The following is a description of a gene set: from publication Senese S, Zaragoza K, Minardi S, Muradore I, Ronzoni S, Passafaro A, Bernard L, Draetta GF, Alcalay M, Seiser C, Chiocca S (PMID 17470557) Human Gene Set: SENESE_HDAC1_AND_HDAC2_TARGETS_UP studied in species Homo sapiens Genes up-regulated in U2OS cells (osteosarcoma) upon knockdown of both HDAC1 and HDAC2 by RNAi. Posttranslational modifications of core histones are central to the regulation of gene expression. Histone deacetylases (HDACs) repress transcription by deacetylating histones, and class I HDACs have a crucial role in mouse, Xenopus laevis, zebra fish, and Caenorhabditis elegans development. The role of individual class I HDACs in tumor cell proliferation was investigated using RNA interference-mediated protein knockdown. We show here that in the absence of HDAC1 cells can arrest either at the G(1) phase of the cell cycle or at the G(2)/M transition, resulting in the loss of mitotic cells, cell growth inhibition, and an increase in the percentage of apoptotic cells. On the contrary, HDAC2 knockdown showed no effect on cell proliferation unless we concurrently knocked down HDAC1. Using gene expression profiling analysis, we found that inactivation of HDAC1 affected the transcription of specific target genes involved in proliferation and apoptosis. Furthermore, HDAC2 downregulation did not cause significant changes compared to control cells, while inactivation of HDAC1, HDAC1 plus HDAC2, or HDAC3 resulted in more distinct clusters. Loss of these HDACs might impair cell cycle progression by affecting not only the transcription of specific target genes but also other biological processes. Our data support the idea that a drug targeting specific HDACs could be highly beneficial in the treatment of cancer., and this is the list of marker genes: KISS1, LINC02915, PRDM1 (PR/SET domain 1), CBFB, PSME4, PTBP1, MAP3K7CL, PDE4DIP, TEX261, PRIM2, TASOR2, ELK3, PI3, BCL2L1, MAFF, IL1RAPL1, EXTL3, RBPMS2, IL6R, RPL27A, BMP2, MCL1, SCYL2, GEM (GTP binding protein overexpressed in skeletal muscle), PLEKHB2, OTUB2, DNAJB14, BCL2A1, HAS2, PPIF, TFRC, SNHG16, SCG5, RRAGD, DOCK4 (NCBI Gene Id 9732), JAM3, SLC16A1, TMEM200A, ATP11B, NTAQ1, MMP9, DDX42, RAC2, NAV3, SAA1, IL13RA2, IRAK2, HIP1 (huntingtin interacting protein 1), GCH1, BIRC3, HHIP, FN1, FGFRL1, AADACP1, BICD2, WAKMAR2, NFKB2, SERPINA1, PPARGC1B, LINC-PINT, RAB35, LINC02535, CPEB4, SIPA1L3, STIP1, CREM (cAMP responsive element modulator), MEGF10, ADAMTS17, GCNA, NAMPT, NAP1L1, ULBP2, PRPF6, UBASH3B, PLAUR, CSF2, GLYR1, SFRP1, LDB2, LARP4, ITPKA, KLHL21, PLEC, SLC16A3, PAX8, IL7R, CD55, HMGA1, PGAP6, ZBTB38 (NCBI Gene Id 79779), ADAMTS6, SPOPL, ZC3H12A, PCGF5, CCND2, CANT1, USP10, PPARA, CXCL3, STK10, FOSL1 (NCBI Gene Id 8061), PAX8-AS1, TNFRSF11B, RPAP3, MTAP (methylthioadenosine phosphorylase), RAB3B, PRRX1, MICAL2, G0S2, OLAH, NFKBIZ, CAMTA1, SH2B3, CHST11, SPRED2, PTPN5, LMAN1, DKK2 (dickkopf WNT signaling pathway inhibitor 2), LINC02577 (long intergenic non-protein coding RNA 2577), C4orf46, CAPN5, SRGN, UEVLD, TMEM158, LINC01088, AADAC, IL1A, PTPN12, OSMR, GFPT2, REEP3, TRIML2, CXCL8, NRIP3, GNA13, MMP1, CTNNA1, DKK1, SH3PXD2A-AS1, PTPRN2, CDC42SE2, UCA1, ZBED2, ENSG00000290941, EPHA4, PRR20A, ELMOD1, AGO2, POU2F2, KYNU, SORBS2 (sorbin and SH3 domain containing 2), ST3GAL1, HSF1, SNAP23, PLAU, ESYT2, RGS2, MYH16, SLC39A4, TAFA5, ITGA6, SPHK1, PSTPIP2, ODAPH, HECTD1, TCN1, ADPRHL1, TNFAIP3, SUPT6H, KDSR, LAMC2, EPHB1, DPY19L1, IL11, DHX9, NKD1, EXOC5, DCLK1, SLC7A2, TMOD1, TWF1, PGF, RDUR, COPA, C3, HOMER3, ADGRL4, LTB, LINC00326, PPTC7, MYCT1, TMEM65 (transmembrane protein 65), TIE1, CCL20, ROBO4, TFAM, PAPOLA, TRIM38, EGFR, TNFRSF12A, EIF4G1, PTX3 (pentraxin 3), PHTF2, COL6A3 (collagen type VI alpha 3 chain), CES1, LPXN, AFF3, TGM2, MC5R, MELTF, TNFRSF10B, IL6ST, SYTL3, IQGAP1, SEC61A1, TGFBR2 (NCBI Gene Id 7048), SUPT16H, WDR6, SPIRE1, IL24, CCNE1, CDV3, LAPTM5, AP1S2, FAM9B, PDE4D, MAOA (monoamine oxidase A), PRR9, MCM4, SMG1, CA2, CEP170, PDLIM4, NUS1, GPAT3, EREG, SKIC3, GPR3, PXN (NCBI Gene Id 80229), SERPINB2, CHRNA9, ANTXR2, FKBP1B, CXCL5